Given this list of marker genes Igf2r, Cd2ap, Rab32, Flot2, Pip4p2, Amelx, Slc15a2, Stxbp2, Slc18a3, Tap1, Tcirg1, Stx4a, H2-Q7, Nod1, Evl, Calr (NCBI Gene Id 12317), Mcoln1, Unc13b, Rab11fip3, Gsn, Syt7, Rapgef2, Scara5, Irgm1, Clec4e, Slc9a9, Unc93b1, Ston1, Was, Appl2, Dpp4, Fmnl1, Ehd3, Ffar4 (NCBI Gene Id 209389), Stam2, Rab34, Amot, Pikfyve, Vamp8, Gapvd1, Tlr7, Stxbp1, Avpr1a, Rab11b, Slc48a1, Tlr6, Cd82, Mpeg1, Rab20, Inpp5f, Ehd2, Slc5a7, Rab24 (NCBI Gene Id 67793), Rilp, H2-D1, Rab39, Capg, Rab31, Smo, Itsn1, Pik3c2b, Ang, H2-T23, Rinl, H2-T3, Rab11fip1, Lrp2, Stx12, Kif5b, Becn1, Cybb, Fth1, Tlr9, Uvrag, Vamp3, Adam8, Pfpl, Plekhg5, Tirap, Rab11fip4, Trf, Havcr1, Dysf, Ecpas, Tlr1 (toll-like receptor 1), Heatr5b, H2-K1, Cubn, H2-Q10, Dnm1, Amn, Csf3r, Vim, Rab8b, Vamp4, Scimp, Rab14, Atg14, Rabep1, Nod2, Hyal2, Sh3kbp1, Ap2m1, Rab7b (RAB7B, member RAS oncogene family), Pip4p1, Vps11, Rab10, Gipc1, Dmbt1, Lamp2, Lrrk2, Slc11a1, Rin2, Rin3, Vps9d1, Ap2b1, Rab5a, Ctss, Anxa3, Coro1a, Ngfr, Pla2g5, Eps15, Rapgef1, Lck, Cpne2, Zdhhc5, Myo18a, Rab43, Arf6, Egfr (NCBI Gene Id 13649), Rab35, Rab5c, Ston2, Clcn3, Dnm2, Cdc42, Stx7, Drd2, Dab2ip, Lmbrd1, Sec61a1, Kifc1, Epn2, Drd3, Tapbp, Kifc2 (kinesin family member C2), Ehd4, Dync1li1, Sgip1 (SH3-domain GRB2-like (endophilin) interacting protein 1), Lpar2, Lamp1, Pld4, Ftl1, Ctla4, Actg1, Tbc1d5, B2m, Hvcn1, Rabgef1, Srgap2, Kif16b, Apoa1, Avpr2, Rab5b, Stx6, Cdc42ep4, Stxbp4, Pik3c3, Flnb, Mtor, Pld1, Snx3, Rab9b, Rala, Rab38, Btbd8, Rap1a, Rnf115, Rab12, Rapgef6, Mtmr4, Myo1e, Cdc42ep2, Stxbp3, Tyrp1, Syt11, Ap2a1, Ocln, Syk, Rab17, Cpne6, Rab9, Rab22a, Anxa11, Tlr2 (toll-like receptor 2), Cemip, Appl1, Nrxn1, Vps26b, Ambra1, Ccl2, Sphk1, Slamf1, Stx8, Rab11fip5, Csf3, Ehd1, Zyx, Scarb2, Rab8a, Abca1, Nlgn3, Rin1, Heatr5a, Rab11a, Ap2a2, Trim14, Lpar1, Myo1c, Rab23, Rab13, Myo6, Arrb2, Rab7, Snap91, Cltc, Ap2s1, Ocrl, Stx11, Inpp5b, Myh9, here is a description of the gene set: A membrane-bounded intracellular vesicle formed by invagination of the plasma membrane around an extracellular substance. Endocytic vesicles fuse with early endosomes to deliver the cargo for further sorting. studied in species Mus musculus Mouse Gene Set: GOCC_ENDOCYTIC_VESICLE